The following is a description of a gene set: This event has been computationally inferred from an event that has been demonstrated in another species.<p>The inference is based on the homology mapping from PANTHER. Briefly, reactions for which all involved PhysicalEntities (in input, output and catalyst) have a mapped orthologue/paralogue (for complexes at least 75% of components must have a mapping) are inferred to the other species. studied in species Mus musculus Reactome Pathway: Sodium/Calcium exchangers electronically inferred by orthology from the curated human pathway part of: Metal ion SLC transporters, and this is the list of marker genes: Slc24a2, Slc24a3, Slc8b1, Slc24a5, Calm1, Slc24a1